Given this list of marker genes EXT1, OGN, B4GALT1, SDC4, VCAN, SLC26A2, EXT2, DCN, HEXA (hexosaminidase subunit alpha), CSPG5, CSPG4, B4GALT7, GPC2, GPC3, LUM, GPC4, SDC3, GPC6, KERA, B3GAT3, PAPSS2, CHST6, HSPG2, OMD, PRELP, CHSY1, FMOD, GPC5, BGN, ST3GAL3, CHST3, BCAN, NCAN, SDC1, AGRN, SDC2, B3GALT6, GPC1, CHST14, HEXB, ACAN, here is a description of the gene set: A number of genetic disorders are caused by mutations in the genes encoding glycosyltransferases and sulfotransferases, enzymes responsible for the synthesis of glycosaminoglycans (GAGs) as well as hexosaminidase degradation of GAGs. Reactome Pathway: Diseases associated with glycosaminoglycan metabolism part of: Diseases of glycosylation species: Homo sapiens